The following is a description of a gene set: Human Gene Set: REACTOME_MITOCHONDRIAL_UNCOUPLING Mitochondrial Uncoupling species: Homo sapiens, and this is the list of marker genes: UCP2, SLC25A27, PM20D1 (NCBI Gene Id 148811), UCP1 (uncoupling protein 1), UCP3, SLC25A4, SLC25A14